The following is a description of a gene set: Pathway Definition from KEGG: HTT* -| CxIII -> CytC Mutation-caused aberrant Htt to electron transfer in Complex III. Pathway ID: N00991. Pathway type: Variant. Pathway class: nt06461 Huntington disease. Human Gene Set: KEGG_MEDICUS_VARIANT_MUTATION_CAUSED_ABERRANT_HTT_TO_ELECTRON_TRANSFER_IN_COMPLEX_III studied in species Homo sapiens, and this is the list of marker genes: UQCRHL, CYC1, UQCR10, MT-CYB, UQCRB, UQCRH, UQCRC2, UQCR11, HTT, UQCRFS1, UQCRC1, UQCRQ